The following is a description of a gene set: Human Gene Set: GSE35685_CD34POS_CD38NEG_VS_CD34POS_CD10POS_BONE_MARROW_UP species: Homo sapiens Studies of adult human hematopoiesis have until now relied on the expression of CD10 to define lymphoid commitment. We report a novel lymphoid-primed population in human bone marrow that is generated from hematopoietic stem cells (HSC) prior to the onset of CD10 expression and B cell commitment, and is identified by high levels of the homing molecule L-selectin (CD62L). CD10-CD62Lhi progenitors have full lymphoid (B/T/NK) potential, and show reduced myeloid and absent erythroid potential. Genome-wide gene expression analysis demonstrates that the CD10-CD62Lhi population represents an intermediate stage of differentiation between CD34+CD38- HSC and CD34+lin-CD10+ progenitors marked by down-regulation of TAL1 and MPL, upregulation of E2A, CD3E and IL2RG expression, and absent B cell commitment or RAG1/2 expression. Immature CD34+CD1a- thymocytes are also CD62Lhi and L-selectin ligands are expressed at the cortico-medullary junction, suggesting a possible role for L-selectin in human thymic homing. These studies identify the earliest stage of lymphoid priming in human bone marrow. from publication Kohn LA, Hao QL, Sasidharan R, Parekh C, Ge S, Zhu Y, Mikkola HK, Crooks GM (PMID 22941246) Genes up-regulated in the bone marrow CD34+ cells: CD38- versus MME+., and this is the list of marker genes: CLCA1, THBS1, FOS, PRKAG1, IL16, URM1 (NCBI Gene Id 81605), SLC2A8, CCDC93, HMOX1, TAF8, BCL2L2, RXRB, AATK (NCBI Gene Id 9625), RSRP1, NHSL3, NSDHL, GNPDA1, ZFPM2, EPHX1, ELOVL3, PRKCZ, NFIC, PEG3, ARHGAP39, ADRA2C, SLC25A44, SLC6A8, NINJ1 (NCBI Gene Id 4814), PEF1, TSPAN6, GNA11 (NCBI Gene Id 93626), EIF4B, NKX1-2, PPARG, CX3CR1, CYP3A4, MRTFA, NIPSNAP1, TYSND1, TUSC2, CRABP2, PTPN22, FAM50B, NUP50, RREB1, TPPP3, DIDO1, MERTK, FRAT1, HCN1, SLC25A20, TECTA, SLC22A2, TWF2, ZFP36L2, DNAJB4, ZFTRAF1, RHOG, PRKCD, PHC1, METTL17, LYL1, TSC22D1, SESN1, HUS1, PNRC1, RGS14, RMND5A, TNC, ZBTB2 (NCBI Gene Id 57621), IL12A, ST3GAL5, DCN, YPEL3, CMAS, KLHL21, MATN1, PARP1, RALBP1, AQP8, KIF22, GOLGA5, VIM, KRTAP8-1, LRWD1, MOGS, CLEC11A, FCER1A, ZNF808, LIN9, MRPL41, COL4A1, ABCC1, PRPSAP2, OSBP, CD160, SLC52A2, ELP3, AP5S1, VPS37B, LPCAT1, SLC6A12, FBXW4, BMAL1, DNASE1L2, AP2B1, CD300C, CKAP4, POLR2I, HBE1 (NCBI Gene Id 3046), REL, MRPL15, UQCC5, PDLIM7 (PDZ and LIM domain 7), SLC27A1, ZNF653, NMBR, CYP7A1, TNFRSF11A, FOXO3, F3, NSMF, MAGED1, PARD6A, PHF12, SLC38A5 (NCBI Gene Id 92745), MYORG, SUN2, SNAPC2, COL22A1, FST, CSNK1E (casein kinase 1 epsilon), ATG4B, RBM38, ABCB10, MCEE, LPIN1, GFM2, DAGLB, COPS7B, IKBIP, SIGLEC1, ERCC1, HSD3B1, KANSL2, TYRO3, CASP9, SFTPB, NBEAL2, SH3BP2, IL10RB, PLEKHO1, IDH2, PTPRE, GTF2I, GPN3, RASD1, KLHL24, NELFA, PRKAR2A, BTG2, CCNE1, MDM2, CA8, ALDH2, MEPCE, CIPC, ZFAND2A, BSCL2, SLC25A39, SEC61A2, ERF, PLP2, TNIP1, LRRC23, PRKCE, EEF1A2, TMEM37, GABBR1, MAPK14, MAEA, SGTA, ZEB1, MAP3K12, PPY, ENTPD7, TGIF1, GRIN2D, SMIM20, KDM3A, IL10RA, GPR143, MKNK2, SFRP1, RASGRP1 (NCBI Gene Id 10125), RHOB, ZNF740, MBP, FBXO15